The following is a description of a gene set: Mouse Gene Set: GOMF_METAL_CATION_MONOATOMIC_CATION_ANTIPORTER_ACTIVITY Enables the transfer of a solute or solutes from one side of a membrane to the other according to the reaction: solute(out) + Na+(in) = solute(in) + Na+(out). species: Mus musculus, and this is the list of marker genes: Slc4a10, Slc8a3, Slc9a9, Slc9a8, Slc9a1, Slc38a5, Slc9a2, Slc41a3, Slc9a3, Slc8a1, Slc9a5, Slc9a7, Slc30a10, Slc30a2, Slc24a1 (NCBI Gene Id 214111), Slc11a1, Slc24a4 (NCBI Gene Id 353057), Slc17a7, Slc30a5, Slc41a1, Slc8a2, Ghitm, Slc9b2, Slc9c1, Slc24a3, Slc30a1, Slc24a2 (solute carrier family 24 (sodium/potassium/calcium exchanger), member 2), Slc9a6, Slc24a5, Slc9a4, Chp1, Slc4a9 (solute carrier family 4, sodium bicarbonate cotransporter, member 9), Slc30a8, Slc17a6, Slc4a8, Slc38a3, Slc8b1, Tmco3, Letm1